Given this list of marker genes TRAP1, POLR1HASP, PRKCA, PDIA5, TENM4, EHD1, ELMO2, HIKESHI, THRSP, MAN2B2, KLK9, ARMC5, GCNT2, JUN, PKP1, TPM3, ERO1A, CBX8, RALGPS1, PIGA, KHK, PLAGL2, SLC25A29, PLEKHA2, ZNF385A, JAG2, MAP1LC3A, ANO10, GSTA2, PDLIM7, COG1, CROCC, GBE1, JMY, INPP5A, CASP6, IL15RA, SEPTIN5, NIN, EFHD2, DNAJC18, P4HA2, HOXA1, GP1BB, ZBTB16, ATXN7, ALX3, ABCD4, GATA2, KRT14, ELAC1, KCNJ14, CYP24A1, PPP1R3C, HYAL1, COPB2, MASP1, MUS81, HILPDA, THA1P, CLDN9, TMEM191C, FCRLA, FLT3LG, MRPL48, NISCH, MAL, MPHOSPH6, NASP, EFHD1, CDC37, CACNA1G, MT1X, LHPP, LCK, BORCS7, MPP2, ZBTB46, TACC3, TNFRSF1B, CNN1, GPR35, ABTB1, TMCC2, VCAM1, EMC4, WIPF1, ABCA2, MYBL1, REM2, CEP70, TXNL1, PDXK, FAM118A, CRHR2, CDR2, TXNDC11, RGS11, CA12, JARID2, CSDC2, SPATA13, GYS1, PROC, DOC2GP, MAPK8IP3, VEGFA, BAG2, PDK1, RAB27B, STC1, BAG5, RSPH6A, PVR, ERAL1, KIF1A, POLR3K, BIN3, ANP32A, ANGPTL2, PORCN, ISG20, SCCPDH, ADAMTS15, HOMER1, THSD1 (thrombospondin type 1 domain containing 1), FOXH1, ID2, ABHD6, SRXN1, SH3KBP1, CAPG, EPB41L4B, DGCR6 (DiGeorge syndrome critical region gene 6), SPDEF, LPIN1, SELENOW, KDELR3, BCL2L2, RABGAP1L, CAPN5, TPD52, MAP1B, EGLN1, NOS2, ABHD18, DNM1, HIGD1A, SLC5A9, F3, HMOX1, PAPOLA, CZIB, GCLC, KLF9, NAAA, MED24, KLK1, ENO3, NDRG1, CARD19, ST6GALNAC4, NDRG4, SERPINE1, PKP2 (NCBI Gene Id 93271), LGALS4, ASS1, TES, PPFIA4, MICAL1, KCNH2, USP43, C16orf74, HSPB8 (heat shock protein family B (small) member 8), GPD1 (NCBI Gene Id 2819), TBL2, RAPGEF3, NAA80, MCAM (NCBI Gene Id 4162), NPHP1, FBXO21, PIGQ, UBXN2A, KIF2A, TAMALIN, NOS3, CYB561, SERPINB1, KRTAP19-1, GALK1, METRN, GZMA, CNDP2, HES6, DGAT2, BNIP3, PGM2, CAV3, EIF2AK3, ATP13A2, PAXIP1, RAB3D, ENO2, CA9, SLC2A1, EDN2, HID1, DUSP9, MYORG, RAB2A, APOBR, TGM2, SLC66A2, STK10, PIGU, CDH5, PCOLCE, SLC1A4, CLDN3, FAM162A, S100A16, HPS1, OMP, NOXO1, PFN2, GPR146, PER2, AS3MT, BCL11A, TM7SF3, OSBPL6, ODF2, CRY2, DUSP1, ELF5, RIC8A, DEPTOR, here is a description of the gene set: Genes down-regulated in ME-A cells (breast cancer) undergoing apoptosis upon serum starvation (5% to 0% FCS) for 22 hr. Human Gene Set: GRAESSMANN_APOPTOSIS_BY_SERUM_DEPRIVATION_DN from publication Graessmann M, Berg B, Fuchs B, Klein A, Graessmann A (PMID 17160024) species: Mus musculus Impairment of the complex regulatory network of cell death and survival is frequently the reason for therapy resistance of breast cancer cells and a major cause of tumor progression. We established two independent cell lines from a fast growing mouse breast tumor (WAP-SVT/t transgenic animal). Cells from one line (ME-A cells) are sensitive to apoptotic stimuli such as growth factor depletion or treatment with antitumor agents (e.g. doxorubicin). Cells from the second line (ME-C cells), which carry a missense mutation at the p53 codon 242, are very insensitive to apoptotic stimuli. Co-cultivation experiments revealed that the ME-C cells mediate cell death resistance to the ME-A cells. Microarray and Western blot analysis showed that osteopontin (OPN) is selectively overexpressed by the ME-C cells. This glycoprotein is the most abundant protein secreted by the ME-C cells and we obtained strong indications that OPN is the main antiapoptotic factor. However, the OPN containing ME-C cell medium does not alter the expression level of pro- or antiapoptotic genes or known inhibitors of apoptosis (IAPs). Its signaling involves mitogen-activated protein kinase (MAPK)/extracellular signal-regulated kinase (ERK) kinase (MEK)1/2 as the kinase inhibitor PD98059 restores apoptosis but not the Akt inhibitor. In the ME-A cells, mitochondrial cytochrome c release occurs with and without external apoptotic stimuli. OPN containing ME-C cell medium does not prevent the mitochondrial cytochrome c release and caspase-9 processing. In serum starved ME-A cells, the OPN containing ME-C cell medium prevents caspase-3 activation. However, in doxorubicin-treated cells, although apoptosis is blocked, it does not inhibit caspase-3. This indicates that the ME-A cells distinguish between the initial apoptotic stimuli and that the cells possess a further uncharacterized control element acting downstream from caspase-3.